The following is a description of a gene set: Human Gene Set: WP_BONE_MORPHOGENIC_PROTEIN_SIGNALING_AND_REGULATION Bone morphogenic protein signaling and regulation studied in species Homo sapiens, and this is the list of marker genes: TOB2 (transducer of ERBB2, 2), SMAD6, SMURF1, NOG, BMPR2, BMP2, SMAD4, TOB1, SMAD1, BMPR1B, RUNX2, BMPR1A